Given this list of marker genes HYAL2, STAB2, FGF2, HEXA, TGFB1, CD44, GUSB, SPAM1, CEMIP, HYAL3, LYVE1, CEMIP2, HEXB, HYAL1, HMMR, HYAL4, here is a description of the gene set: Human Gene Set: GOBP_HYALURONAN_CATABOLIC_PROCESS The chemical reactions and pathways resulting in the breakdown of hyaluronan, the naturally occurring anionic form of hyaluronic acid. Hyaluronan is a type of non-sulfated glycosaminoglycan composed of the repeating disaccharide unit beta(1,4)-D-glucuronic acid-beta(1,3)-N-acetyl-D-glucosamine. species: Homo sapiens